Given this list of marker genes Tifab, Ttn (NCBI Gene Id 99250), Hrc, Camk2d, P2rx4, Akap6, Rgs2, Pawr, Gsn, Grk2 (NCBI Gene Id 11557), Irag1, Nppc, Camk2g (NCBI Gene Id 218813), Pik3ca, Pde5a, Abcc8, Kcnma1, Pde4d (NCBI Gene Id 320753, phosphodiesterase 4D, cAMP specific), Atp1b1, Sri, P2ry1, Sln, Sod1, Pln, Adora2b, Slc8a1, Actn3, Gucy1a1, Kcnj2, Kbtbd13, Atp2a1, Prkg1, Chga, Atp2a2, Neurog1, here is a description of the gene set: A process in which the extent of muscle contraction is reduced. Muscle relaxation can involve a number of processes including the removal of calcium from the cytoplasm to the sarcoplasmic reticulum lumen through the action of Ca2+ ATPases. In some muscles, calcium-independent pathways also play a role in muscle relaxation by decreasing the phosphorylation state of myosin light chain. species: Mus musculus Mouse Gene Set: GOBP_RELAXATION_OF_MUSCLE